Given this list of marker genes C1qtnf4, Atp8a2, Ghrl, Hcrt, Ghsr, Adora2a, Oprl1 (NCBI Gene Id 18389), Drd1, Sgip1, Pyy, Guca2b, Oxtr, Mtor, Bbs12, Prlh, Fto, Stat3, Tmem18, Oprk1, Oprd1, Col6a1, Aoc3, Dgat1, Iapp, Uchl3, Rmi1, Gdf15, Trh, Nmu, Oxt (oxytocin), Napepld, Bbip1, Nmur2, Tacr1, Npy5r, Cntn2, Cpt1a, Lep, Hrh3, Th, Ace, Bsx, Npsr1, Lepr, Adrb3, Gfral, Cckar, Oprm1, Cck, Mc4r, Uchl1, Agrp, P2ry1 (purinergic receptor P2Y, G-protein coupled 1), Ttc21b (NCBI Gene Id 73668), Slc24a4, Npy, here is a description of the gene set: studied in species Mus musculus The specific behavior of an organism relating to the intake of food, any substance (usually solid) that can be metabolized by an organism to give energy and build tissue. Mouse Gene Set: GOBP_EATING_BEHAVIOR